The following is a description of a gene set: from publication Lee JH, Ulrich B, Cho J, Park J, Kim CH (PMID 21768398) species: Homo sapiens Genes down-regulated in CD4 T cells: untreated versus progesterone. Human Gene Set: GSE22025_UNTREATED_VS_PROGESTERONE_TREATED_CD4_TCELL_DN We examined the global gene expression pattern of T cells regulated by progesterone to gain further insights into the regulatory mechanisms of progesterone. We found 325-347 cord blood T cell genes up or down-regulated by P4 in the presence or absence of exogenous TGFb1. Peripheral blood T cells were relatively unresponsive with only 30-genes regulated by P4. IL-6 receptor (IL-6R) expression was greatly down-regulated by progesterone in cord blood, but not PB, T cells. Overall, these differences in gene expression are consistent with the differential responses of cord blood and peripheral blood T cells to progesterone. To gain insights into the differences of progesterone and control dendritic cells, we performed a microarray study and found ~genes regulated by progesterone in dendritic cells. The gene expression information suggests that progesterone has the potential to alter dendritic cell responses to cytokines, chemokine production, and migration which in combination would control T cell differentiation., and this is the list of marker genes: FBXL4, ATP6V1H, DDX39A, CD8A, ASB1, DYNLT1, LTA4H, RRS1, SUSD6, GPR183, NQO1, GRB10, RBM39, ADAM19, CD47, ATF5, ABLIM3, RAB5A, CHST10, ABCD3, YES1, SLA, ZPR1 (NCBI Gene Id 95155), MYD88, H1-4, GNAQ (G protein subunit alpha q), HSP90AA1, TUBB4B, UAP1, CLIC1, SLC6A3, PRRC2C, CD101, BICD2, ELL2, HSPE1, ENPP1, YWHAH, SCGB1D2, IGSF3, UFD1, SLC17A3, UBB, BCL2A1, CDC45, MLX, SLC16A4, GFI1, ANXA1, TUSC3, PITRM1, POLD2, TIAM1, FCER1A, GCN1, ADH7, LHFPL2, SERPINB10, TMPRSS11D (NCBI Gene Id 9407), PAK5, WASF2, ATP5MJ, XCL2, PRRC2B, CLNS1A, GPN1, DLC1, ACSL1, CTDP1, AXIN1, SOSTDC1, GOT2, COX17 (NCBI Gene Id 10063), FNDC3A, GSPT1, ABRAXAS2, RSAD2, IL10RA, JUN, GIT2, RPL9, RRP12, SOCS1, MINDY2, SEC62, RPP14, FURIN, LRP2, RPL39L, PTGER2, SLC39A8, GGPS1, STARD13, DYRK3, TAF1B, ST8SIA1, SELL, CYP2C8, DAP3, TP53BP2, OPRD1, INSIG1, ZCCHC14, PLP2, TFAM, MMP20, EIF4E, KXD1, TUBA4A, MATK, RGS6, HESX1, IER2, BASP1, PPP2R2B, H3-3B, IL1RAP, FUT4, PHLPP2, S100P, RGS16, TARS1, BMPR2, HBEGF, CD58, CREBL2, DIXDC1, PPP1R16B, OXCT1, LY86, GADD45G, ASF1A, PI4KB, ALG13, SMAD7, GNAI1, SCG2, DR1, CALM2, RPL36AL, PDXK, GPX4, CSE1L, TIMP2, NECTIN3, CCT3, GRM5, ARID3A, FICD, RANBP2, DYRK2, XCL1, YWHAQ, CTSL, ATP6V0A2, LYPLA1, MINPP1, ATP2B4, EIF4EBP2, NFATC3, PTP4A1, CSTF2T, RRAGD, EVI5, GNA15, DDB1, IGFBP2, SPINT2, TMCO1, NCLN, MROH7, RPS23, BATF, CHERP, SRP54, PLCL2 (NCBI Gene Id 23228), STMN2, CHRNB4, ZER1, RPL31, RPL36A, ZNF391, SRSF1, PCYT1A, CSTB, SLC7A5, S1PR1, BRINP1, TNFSF11, EIF2S1, IFNA1, ETFB, EFNA1, F5, S100A11, LAPTM4B, CBFB, NDUFS8, SREK1, H2AC13